The following is a description of a gene set: Any process that activates or increases the frequency, rate or extent of amyloid-beta clearance. Mouse Gene Set: GOBP_POSITIVE_REGULATION_OF_AMYLOID_BETA_CLEARANCE studied in species Mus musculus, and this is the list of marker genes: Ttpa, Apoe, Il4, Rock1, Trem2, Abca7, Lrp1